The following is a description of a gene set: Genes up-regulated in atherosclerosis macrophages: anti miR-33 versus untreated. Inhibition of miR-33 results in increased cholesterol efflux and HDL-cholesterol levels in mice. In this study we examined the effect of miR-33 inhibition in a mouse model of atherosclerosis and observed significant reduction in atherosclerotic plaque size. At the end of the study, gene expression in macrophages from the atherosclerotic plaques was assessed. The results demonstrated a reduction in inflammatory gene expression and increased levels of mRNAs containing miR-33 binding sites. studied in species Homo sapiens Human Gene Set: GSE28783_ANTI_MIR33_VS_UNTREATED_ATHEROSCLEROSIS_MACROPHAGE_UP from publication Rayner KJ, Sheedy FJ, Esau CC, Hussain FN, Temel RE, Parathath S, van Gils JM, Rayner AJ, Chang AN, Suarez Y, Fernandez-Hernando C, Fisher EA, Moore KJ (PMID 21646721), and this is the list of marker genes: POSTN, RPL36A (NCBI Gene Id 6173), OXCT1, MYOM2, INPP5B, TNFAIP1, NR4A1, BAP1, UBE2H (ubiquitin conjugating enzyme E2 H), GNG4, ADGRE5, TFPI, B3GALNT1, RABEPK, SBF1, BICRAL, SSX1, MRTFA, LIFR, MAPRE2, CLUL1, INSIG1, TSC1, UHRF2, REG1A, CLSTN1, PDXDC1, HSDL2, ZNF165, CYP2B7P, KIF22, MARCHF2, MAD1L1, GADD45A (growth arrest and DNA damage inducible alpha), PLEK, TNFRSF1B, FABP1, PPP1R2C, GULP1, PRIM1, KHK, TNF, SOX30, APLNR (NCBI Gene Id 187), MAGEB1, CCND1, CRIPTO, ITPKB, POP4, PDZK1, ITPR3, SULT1A1, LASP1, GPX1, ISG15, SPOUT1, FCGR1A (NCBI Gene Id 50698), ATP7B, LCT, TERF2IP, PRKAA2, GPR37, ZNF189, DIO1, CDC6, LPXN, GADD45B (growth arrest and DNA damage inducible beta), RELN, ECI1, MAP2K2, RNASE3, FZD1, GNRH1, ZBTB7B, ALDH1A1, LDHC, RHOC, GPR4, PSEN1, ZNF35, ORC3, KLC1, ATOX1, NDUFS8, ATP1A3, DRD1, TOM1, TGIF1, PRKN, HOXB2, RAB32, MAEA, EXTL1, KIT, APOBEC3B, FGFR1, TGFBR1, DNAJC9, ABL1, EXO1, GYPC, VILL, PFDN4, GABARAP, IL5, DNA2, COL9A3, SUSD5, RGS10, KATNIP, TCF4, CXCL2, NINJ1, TIMP1, EPHB6, TPGS2, CLCC1, IFNA6 (interferon alpha 6), KHDRBS3, CHGB, CXCL13, SLC15A2, POU2F2, ACTN3, DDIT4, IFNGR2, SLC16A3, NDRG1, CSNK2A2, ITGB7, ESM1, EMP1, GDF10, PTPN14, PAH, IFT27, CD72, SIVA1, MFNG, NR0B1 (NCBI Gene Id 8238), RARG, RUNX3, GRM7, FGF7, TLR5 (NCBI Gene Id 95519), GSE1, R3HCC1, CD81, CRIP1, PAFAH1B3, RBM38, CD1E, MYL12B, INPP5K, HSPB6, TFPI2, NEFL, CDK2AP2, H1-2, SIK3, DUSP5, RTN2, CD5L, MYBL2, HMGB3P30, SURF2, ID3, MEST, CSF3R, GCNT2, UBE3A, ACVR1B, RWDD2A, RRP8, GSS, ARMCX4, MAD2L1, PCCB, CD6 (NCBI Gene Id 923), SMAGP, KIF20B, PI4KB, SCGB2A2, LMO2, ELP4, NID2, VAC14, PHKG1, APOM, GRK4, RBM17, MEGF8, TIMELESS, LDB1, KIAA0087, FLT1, CBX5, BCHE, DAB2